Given this list of marker genes LOXL2, CENPV, LYST, RGS2, SRCAP, PLOD2, EGFR, CTNNAL1, STEAP1, LMO7, WWTR1, PHLDB2, NABP1, SLC12A6, ANKRD22, IDS, TSC22D2, UBE2E3, STC1, ENC1, EPHA1, CAVIN1, DSC2, HOMER3, ISG20, VDR, BCL2A1, DNM3, B3GNT5, PLAUR, CD59, S100A2, FAM131B, NT5E, C3orf52, RAB3B, IL1R2, SLC4A7, AP1S3 (adaptor related protein complex 1 subunit sigma 3), ACTN1, LGR4, NPY1R, HK2, FSTL3, ERO1A, MEAK7, TFPI (tissue factor pathway inhibitor), PTGES, MET, EDEM1, HSPB8, IGF2BP2, TSPAN3, TGFA, ZNF185, ITGB6, ANGPTL4, SH2D3A, ITGB1, ENTPD3, TNFAIP8 (NCBI Gene Id 25816), TMEM156, COL13A1, MMP1, ITGA5, LHFPL6 (NCBI Gene Id 10186), PARM1, GPX3, CD44, ST20-AS1, ADAM9, F2RL1 (NCBI Gene Id 7901), TSPAN1, MGLL, IL11, here is a description of the gene set: from publication Pedersen K, Angelini PD, Laos S, Bach-Faig A, Cunningham MP, Ferrer-Ramón C, Luque-García A, García-Castillo J, Parra-Palau JL, Scaltriti M, Ramón y Cajal S, Baselga J, Arribas J (PMID 19364815) Human Gene Set: PEDERSEN_TARGETS_OF_611CTF_ISOFORM_OF_ERBB2 studied in species Homo sapiens HER2 is a tyrosine kinase receptor causally involved in cancer. A subgroup of breast cancer patients with particularly poor clinical outcomes expresses a heterogeneous collection of HER2 carboxy-terminal fragments (CTFs). However, since the CTFs lack the extracellular domain that drives dimerization and subsequent activation of full-length HER2, they are in principle expected to be inactive. Here we show that at low expression levels one of these fragments, 611-CTF, activated multiple signaling pathways because of its unanticipated ability to constitutively homodimerize. A transcriptomic analysis revealed that 611-CTF specifically controlled the expression of genes that we found to be correlated with poor prognosis in breast cancer. Among the 611-CTF-regulated genes were several that have previously been linked to metastasis, including those for MET, EPHA2, matrix metalloproteinase 1, interleukin 11, angiopoietin-like 4, and different integrins. It is thought that transgenic mice overexpressing HER2 in the mammary glands develop tumors only after acquisition of activating mutations in the transgene. In contrast, we show that expression of 611-CTF led to development of aggressive and invasive mammary tumors without the need for mutations. These results demonstrate that 611-CTF is a potent oncogene capable of promoting mammary tumor progression and metastasis. Genes up-regulated in MCF7 cells (breast cancer) more than three-fold by the truncated form 611-CTF of ERBB2 and less than two-fold by the full-length ERBB2.